Given this list of marker genes Nox1, Psmc5, Hsf1, Cdc34, Cdc34b, Hap1, Apoe, Clu, Psmc6, here is a description of the gene set: Any process that increases the rate, frequency, or extent of inclusion body assembly. Inclusion body assembly is the aggregation, arrangement and bonding together of a set of components to form an inclusion body. Mouse Gene Set: GOBP_POSITIVE_REGULATION_OF_INCLUSION_BODY_ASSEMBLY species: Mus musculus